Given this list of marker genes IFT74, SCD, SH3GL1, SMAD7, LURAP1L, FOXE1, SNX33, TXNRD2, UIMC1, MAP3K7CL, BCKDK, CYTH3, ZFP91, SLC6A8, DBNDD2, KLF13, MTCL1, TRPC1, MAFF, GLTP, ASAP2, PRR7, MEX3D (mex-3 RNA binding family member D), PLEKHA8, DUSP1, TMEM102, MXI1, CTDSP1, RAVER1, PLIN2 (perilipin 2), DAPK1, RHOF, MYBL2, LPCAT1, VPS13D, PERP, SIRPA, IFNAR1, TNNT1, PADI1, SLC25A36, NR3C1, TANC2, ACAT2, MASTL, H2AC18, VIM, WDR90, PDLIM2 (PDZ and LIM domain 2), PAXIP1, RABGEF1, ATAD2, CCNG1, CAPN12 (calpain 12, NCBI Gene Id 337935), TNFRSF10D, FAM162A, FAXC, DDB2, CCND1, E2F7, MRPL37, SLC29A4, MLYCD, TOB2, ISG20, PPFIA4, PDK2, MPP1, GAPDH (glyceraldehyde-3-phosphate dehydrogenase), MTHFD1L, ARHGAP27, TUBBP1, NARF (NCBI Gene Id 26502), STARD13, ZFTA, NIPAL3, HSPA12A, SEC14L1, CD44, TMEM120B, ASF1B, KIAA1958, RYBP, PDK1, SLC10A3, GEMIN7, ITGA3, MEF2D, MCM5, GPER1, TACC1, MAP3K4, PSG7, BOK, TICAM1, PLOD2, MTUS1, PNMA2 (PNMA family member 2), CENPQ, TREX1, SPG7, NFKBIA, SAMTOR, NDC1, LSR, CRKL, ACTG1, USP36, CEP112, RRP1 (ribosomal RNA processing 1), RGMB, FAM234B, LGALS3, HOOK3, DENND4C, ELP5, SAP30, CENPU, ALDOA, DPYSL2, MAP3K21, TMSB10, DPYSL3, PRR11, SHFL, MARCHF9, CSRP2, JUN, SPNS2, UBE2J1, NID1, GGA2, ANKLE2, AZIN2, INSIG2, ANG, SOAT1, WAC, WDR54, TBC1D9B, RBPJ, DOC2A, GSN, ECT2, MSMO1, CHN1, SLC38A2, MFNG, PPTC7, TRAF3, QKI, MELK, CRTC2, MAPK1, STK10, RN7SK, EHBP1L1, PLP2, JMJD6, PFKP (phosphofructokinase, platelet), RIC1, ENOSF1, ATRX, SDC1, NUAK1, ERGIC1, ATP1B1, SLC6A10P, PMP22, PHF13, DHFR, RNF4, SPIRE1 (spire type actin nucleation factor 1), PPP1CC, DIPK2A, TPI1, TGFB1, PGK1, FAM83H, MTFP1, GBE1, TSR1, ZNRF1, NEFL, OSMR, FGF12, DTL, ANKZF1, IER5L, PIH1D1, SLC2A1, SIAH2, BFSP1, IRX3, FAS, GCLC, SHANK2, ADPRS, H3-3B, NUDT18, TUBA8, ALDH18A1, PPP2R5B, CRAMP1, MYH9, ADAMTS3, POGLUT3, PMEPA1, TTYH3, CTHRC1, TUBB4B, HILPDA, GSK3B, PEX3, PKMYT1, MYH10, SLC35E3, LDHC, CSPP1, FAM117B, DYRK2, PRELID2, DISC1, HK1, ING2, SMYD2, ELFN2, PDGFC, RNF126, ABCB6, OGFR (NCBI Gene Id 51783), KTN1, RIN2, CCDC85C, MMP24, H1-2, UBA6, CA9, SELENOH, DSC2, DCAF7, SOWAHC, PACS1, GPR161, STBD1 (NCBI Gene Id 8987), WDR43, DEGS1, TPI1P1 (NCBI Gene Id 86116), CUL4A, FTSJ1, IGFBP3, SPRY1, NEDD4, PRKAA2, KIAA0513, CRYBB2, BNIP3L, LAT, PLAGL1, CCDC107, PTPN14, NTAN1, YEATS2, BIRC5, SLX9, PANX2, MXRA7, SLC39A8, CCN2, DIAPH2, PALM2AKAP2, CENPF, RERG, DERA, EVA1A, EHD2, PFKFB3, RAB42P1, TMEM185A, LRRC61, SRGAP2, SNHG7, RAPH1, IFIT2, NT5DC2, ASXL1, ZMYM2, USP31, KIF11 (kinesin family member 11), MAPK7, SOX12, TSC22D2, FGFRL1, TESK1, OIP5, NUSAP1, AXIN1, PCGF5, P4HA1, SLC16A1, MLLT3, TMSB4XP1, FJX1, CCDST, CARD10, WWC2-AS2 (WWC2 antisense RNA 2), SPAG1, TMEM44, TLCD3A, IRS2, PHF19, UPRT, TES, CXCL1, PGAM1, ORC1, CITED4, RAPGEF1 (NCBI Gene Id 2889), LOXL2, KCMF1, SLCO4A1, SORBS3 (sorbin and SH3 domain containing 3), IFNGR2, ARID5A, MSANTD3, MTMR1, TGIF2, PIGH, SLC3A2, ALDOC, TNFAIP8, LEMD1 (LEM domain containing 1), FADS2, RASA3, SCARA3, MKLN1, NCKIPSD, IL17RA, FOXD1 (NCBI Gene Id 2297), KCNIP1, NDRG1, CDC42EP1, STC2, MRGBP, ICAM1, CNN3-DT, RNASET2, TMX1, SLC39A13, EPAS1, ATG9A, PAN3, FBRSL1, PRC1, SGF29, EIF4EBP1, SYT12 (NCBI Gene Id 91683), ZNF292, TCF19, CACHD1, FBXO42, RIMKLA, RACGAP1, HIVEP2, DNAJB6, HS3ST3A1, PRKAR1B, MYADM, BUB1, BTN2A2, LDHA, UHRF1, UBALD2, P4HA2, FSCN1, SMURF2, CTDSPL2, LHFPL6, MGLL, GPRC5B, ZFP82, KLF6, KBTBD11, ECE2, FAM219A, SNTA1, GPRC5A, MAPK8IP3, C2orf15, KCNMA1, TYMS, BHLHE40, IER5, CDCP1, MIR23AHG, CARS2, SLC26A6 (solute carrier family 26 member 6), ARID3B, MAP2K1, DDX41, PGM1, IL1RAP, FAM107B (family with sequence similarity 107 member B), PEA15, OSBPL10, SMS, RUNX1, NRSN2, WDR45B, CDCA5, KDM2B, DRAM1, CEP95, DHRS13, IL6, CDT1, FLNA, EFEMP2, DDIT4, ZNF581, C1QL1, RASSF7, FHL1, ZNF114, REC8, ZNF367, RRAGA, ITGB2 (NCBI Gene Id 3689), STK39, NIPA1, PAQR4, EFNA3, HK2, THBD, MARCHF6, JUND, QSOX1, SERTAD2, ERCC5, EMP3, ABTB2, IKBIP, MIR155HG, TMSB15B, PDXP, MITF, RNF149, CCDC102A, CHST14, UAP1, CP, BTBD6, H2BC5, TNIP1, VEGFB, BZW1, ALDOAP2, ARHGEF7, LOX, ENO1, PHF21A, SYTL2 (NCBI Gene Id 84564), AKAP12, CADM1, PBOV1, TACC3, SGSM2, MPI, PAGR1 (PAXIP1 associated glutamate rich protein 1), PGPEP1, SEMA6A (NCBI Gene Id 57556), CNOT11, RETREG1, CTNNAL1, IRAK1, PPP1R13L, APOL2, CCDC9B, CDK2AP1, CASK, SUMO3, MOB3A, CAPN5, PPP1R3C, FOXN3, ARFIP2, TRIP13, CEP55, KDM5B, TRIOBP, WTAP, NOL3, ZNF48, MYC, KCTD15, IMP3, USP1, SNHG5, CCDC80, ADAM10, KIFC1, KCNMB1, MAFK (NCBI Gene Id 7975), CHSY1, CDK18, MFSD12, INSIG1, RASSF2, SLC25A29, RAB3B, HJURP, ZNF496, TNFAIP6, SOD2, SPAG4, NHS, PAM, FOXM1, RBM15B, PTP4A2, PEDS1, SMOX, TMEM41B, RAD51, LHFPL2, RAP2A, VDAC1, ZNF229, PNRC1, CTNNB1, AVPI1, BCL2L1, TRIB3, SPATA2L, SLC7A5, FZD1, FAM53B, POLG, PHC2, NEURL3, RAB42, FBXL16, TIPARP, SEC61G, IER3, N4BP2L2, TGFA, CAMK1D, CABLES1, TUBA4A, VKORC1, VPS26C, RAB11FIP5, KRBA1, B4GALNT4, BPNT2, MBD2, BACE2, NFIL3, TMEM45A, CDS2, KCTD3, ANKRD10, SYNC, RFC1, CCN3, RAB9A, NCAPG2, ITGB5, PDCD10, JAK1, ZNF655, MAP3K3, MICAL3, DAPK3, JPT2, TUBB3, DPCD, NR1H4, THOC6, SLC1A1, POLR2H (RNA polymerase II, I and III subunit H), UBE2O, KIF18B, ANXA3, ANGPTL4, BACH1, ASAP1, ELL2, BFAR, ANTXR1, C11orf68, AP1S2, FBXO17, PCIF1, POU5F1B, LUC7L, FAM224A, TENT4A, APOL1, KCTD11 (potassium channel tetramerization domain containing 11), SPHK1, ZSWIM5, SLC39A1, WSB1, LNPK, GLIS2, TNFAIP3, STARD4, PDIA3, BNIP3, TCF3, CEP250, TK1, ANO6, RAB6C, HSD3B7, GALNT18, GADD45A, ADARB1, AIFM2, SRSF3, RRAS2, SWAP70, PLEKHO1, PGM2, ALKBH5, ZYX, LGALS1, SLC15A4, RNF24, PPP1R3B, RASSF1, ARRDC3, ARL4C, FNBP1, LONP1 (lon peptidase 1, mitochondrial), NEXN (nexilin F-actin binding protein), SLC31A2, ZP1, ZC3H7A, GAPDHP23 (NCBI Gene Id 391075), SLC43A3, SEMA5A, AMPD2, MUC1, BID, NEK6, TBC1D8, POLE, MKRN1, GAL3ST1, PPP1R14B, LACTB, FBXL3, PTTG1IP, SUSD1, EEF1AKMT3, TUBB, CAVIN1 (caveolae associated protein 1), TAB2, GNA13, FANCI, SPRED2, CCNY, RIC8A, AK4, DAB2IP, CCNG2, PAX2, SERPINE2, ZHX2, TPD52, ZMIZ2, GAB2, CIC, GRK3, CALM1, SLC39A14, GMCL1, RCC2, SAV1, SMTN, MNS1, RIT1, CYTH2, CXCL6, SEMA5B, BMAL1, CHRAC1, MRPS6, IMPDH1, OLFML2A, TP53BP2, PPP3CC, PPP1R16A, FUT11, TSHZ3, FBXO32, FBXL21P, KAT2B, HNF1B, ZNF629, SNHG12, EPHA2, TPM1, MGAT5, KDM2A, SLC22A5, OXSR1, TEX10, HNRNPDL (NCBI Gene Id 9987), ING1, FAM210A, KCNIP3, FGF11, KIAA1671, TUBB6, CAST, ZNF296, POU5F1, NFIA, PKM, TUBB8P11, AGPAT5, SLC38A1, EGFR, ADD3, EGLN1, RAB20, NIBAN2, GYS1, CCR1, CLK3, ACTG1P10, RIPK4, RNU2-1, KNTC1 (kinetochore associated 1), SLC35E1, GRSF1, TRIO, MYOF, RNF169, ETS1, IFITM10, ENO2, here is a description of the gene set: species: Homo sapiens The hypoxia-inducible transcription factors (HIFs) directly and indirectly mediate cellular adaptation to reduced oxygen tensions. Recent studies have shown that the histone demethylase genes JMJD1A, JMJD2B, and JARID1B are HIF targets, suggesting that HIFs indirectly influence gene expression at the level of histone methylation under hypoxia. In this study, we identify a subset of hypoxia-inducible genes that are dependent on JMJD1A in both renal cell and colon carcinoma cell lines. JMJD1A regulates the expression of adrenomedullin (ADM) and growth and differentiation factor 15 (GDF15) under hypoxia by decreasing promoter histone methylation. In addition, we demonstrate that loss of JMJD1A is sufficient to reduce tumor growth in vivo, demonstrating that histone demethylation plays a significant role in modulating growth within the tumor microenvironment. Thus, hypoxic regulation of JMJD1A acts as a signal amplifier to facilitate hypoxic gene expression, ultimately enhancing tumor growth. Human Gene Set: KRIEG_HYPOXIA_NOT_VIA_KDM3A Genes induced under hypoxia independently of KDM3A in RCC4 cells (renal carcinoma) expressing VHL. from publication Krieg AJ, Rankin EB, Chan D, Razorenova O, Fernandez S, Giaccia AJ (PMID 19858293)